The following is a description of a gene set: Human Gene Set: GOBP_LIPID_PHOSPHORYLATION studied in species Homo sapiens The process of introducing one or more phosphate groups into a lipid, any member of a group of substances soluble in lipid solvents but only sparingly soluble in aqueous solvents., and this is the list of marker genes: DGKQ, DGKA, DGKH, DGKD, DGKZ, DGKE, DGKB, DGKI, AGK, DGKG